The following is a description of a gene set: Short phalanx of the thumb studied in species Homo sapiens Human Gene Set: HP_SHORT_PHALANX_OF_THE_THUMB Hypoplastic (short) thumb phalanx., and this is the list of marker genes: SMC1A, PIK3CD, SOX9, PTCH1, SETBP1, ACVR1, GNAS, SF3B4, SMC3, NIPBL, RTL1, PCNT, VPS35L, ERI1, NOG, DLK1, IHH, SALL4, SRCAP, TBX5, KCNH1, FANCI, HDAC8, TAF6, RAD21, MEG3, BMPR1B, HOXA13, MAP3K7, BRD4, CANT1, ROBO1, FZD2, LAMA5, GDF5, FLNA, KNSTRN